The following is a description of a gene set: from publication Wang GG, Pasillas MP, Kamps MP (PMID 15755900) studied in species Mus musculus Mouse Gene Set: WANG_IMMORTALIZED_BY_HOXA9_AND_MEIS1_UP Up-regulated genes in myeloid progenitors immortalized by HOXA9 vs those immortalized by HOXA9 and MEIS1. Meis1 is a homeodomain transcription factor coexpressed with Hoxa9 in most human acute myeloid leukemias (AMLs). In mouse models of leukemia produced by Hoxa9, Meis1 accelerates leukemogenesis. Because Hoxa9 immortalizes myeloid progenitors in the absence of Meis1 expression, the contribution of Meis1 toward leukemia remains unclear. Here, we describe a cultured progenitor model in which Meis1 programs leukemogenicity. Progenitors immortalized by Hoxa9 in culture are myeloid-lineage restricted and only infrequently caused leukemia after more than 250 days. Coexpressed Meis1 programmed rapid AML-initiating character, maintained multipotent progenitor potential, and induced expression of genes associated with short-term hematopoietic stem cells (HSCs), such as FLT3 and CD34, whose expression also characterizes the leukemia-initiating stem cells of human AML. Meis1 leukemogenesis functions required binding to Pbx, binding to DNA, and a conserved function of its C-terminal tail. We hypothesize that Meis1 is required for the homing and survival of leukemic progenitors within their hematopoietic niches, functions mediated by HSC-specific genes such as CD34 and Fms-like tyrosine kinase 3 (FLT3), respectively. This is the first example of a transcription factor oncoprotein (Meis1) that establishes expression of a tyrosine kinase oncoprotein (FLT3), and explains their coexpression in human leukemia. This cultured progenitor model will be useful to define the genetic basis of leukemogenesis involving Hoxa9 and Meis1., and this is the list of marker genes: Bscl2 (NCBI Gene Id 67517), Slfn4, Akr1c13, Thbs1, Cd177, Tnfsf13, Ccnb1, Rhoj (ras homolog family member J), Pde2a, Csf2ra, Ccnd2, Tfec, Sort1, Elane, Bmi1, Myb, Gda (guanine deaminase), Tgfbr3, B4galt6, Mtus1, Ms4a3, Prtn3, Ctnnd1, Clec7a, Kmt2a, Rnf128, Tlr4, Alas1, Abca13, Igsf6, Hsd11b1, Mpo